Given this list of marker genes Gsk3b, Xpo4, Wipf1, Rbm22, Camk4, Anp32b, Camk1, Rapgef3, Mdm2, Ywhae, Prkd1, Ctdspl2, Prkaca, Sirt6, Gas6, Tpr, Ppm1a, Sfn, Emd (NCBI Gene Id 13726), Prpf4b, Bag3, here is a description of the gene set: studied in species Mus musculus Mouse Gene Set: GOBP_POSITIVE_REGULATION_OF_PROTEIN_EXPORT_FROM_NUCLEUS Any process that activates or increases the frequency, rate or extent of directed movement of proteins from the nucleus into the cytoplasm.